Given this list of marker genes LRP4, SCUBE3, FGFR1, ERCC3, IRF6, PEX1, ERCC4, TARS1, IRX5, OCRL, KCNJ2, MMP1, SUMO1, WNT10B (Wnt family member 10B), PIK3C2A, CLDN1 (NCBI Gene Id 9076), ITGA6, FGF10, PAK2, VDR, NECTIN4, SATB1, SMARCA2, CTSK, FLNB, LAMC2, AXIN2, PAX9, GTF2H5, LRP6, LONP1, CHD3, CEP152, FGFR3, TGFA, ITGB4 (integrin subunit beta 4), POLD3, STX16, ROGDI, ERCC1, KRT14, LAMA3, GRHL2, EDARADD, FOSL2, AMELX, TP63, SMOC2, LAMB3, SLC10A7, GJA1, COL7A1, LMX1B, TTC7A, FGFR2, HLA-DQA1, HLA-DQB1, CYP27B1, KRT5 (NCBI Gene Id 3852), OFD1, WNT10A, GALNT3, GTF2E2, ALDH3A2, ATR, ACP4, GNAS, RHOA, MSX1, ERCC6, EP300 (NCBI Gene Id 2033), DDX59, ERCC2 (NCBI Gene Id 7269), FBXO28, PTDSS1, ERCC8, SLC35A2 (solute carrier family 35 member A2), NF1, ODAPH, ITGB6, AIRE, CTBP1, CREBBP, DLX3 (NCBI Gene Id 1747), AARS1, RUNX2, PORCN, CYP2R1, COG6, PCNT (NCBI Gene Id 9346), COL17A1, PGAP1, PLEC, SP6, TRIM37, CARS1, GNB2, FAM20C, RNF113A, NUP133, DNAJC21, MPLKIP, EDA, CLDN16, IFT122, AMBN, here is a description of the gene set: Developmental hypoplasia of the dental enamel. Enamel hypoplasia Human Gene Set: HP_ENAMEL_HYPOPLASIA studied in species Homo sapiens